The following is a description of a gene set: Genes up-regulated in lung adenocarcinoma cell lines and not expressed in non-cancerous lung epithelial cells. species: Homo sapiens Human Gene Set: NAKAMURA_LUNG_CANCER To identify tumor markers and differentiation markers for lung adenocarcinoma (AdC), we analysed expression profiles of genes against three cases of type II alveolar epithelial cells, bronchiolar epithelial cells, and bronchial epithelial cells, respectively, and 10 cases of AdC cells isolated by laser capture microdissection. Hierarchical clustering analysis indicated that AdC cells and noncancerous lung epithelial cells are significantly different in their expression profiles, and that different sets of differentiation markers are expressed among alveolar, bronchiolar and bronchial epithelial cells. Nine genes were identified as being highly expressed in AdC cells, but not expressed in noncancerous lung epithelial cells. Sixteen genes were identified as differentiation markers for lung epithelial cells. Real-time RT-PCR analysis of 45 lung AdC cases further revealed that expression of four tumor markers in AdC cells was significantly higher than that in noncancerous lung cells and that expression of ten differentiation markers was retained in a considerable fraction of lung AdC cases. Five tumor markers and seven differentiation markers were not expressed in peripheral blood cells. Similarities and differences in expression profiles between normal epithelial cells from different lung respiratory compartments and AdC cells demonstrated in this study will be informative for the molecular diagnosis of lung AdC. from publication Nakamura N, Kobayashi K, Nakamoto M, Kohno T, Sasaki H, Matsuno Y, Yokota J (PMID 16491115), and this is the list of marker genes: MCM6, TOP2A, SCG5, COL11A1, ATP10B, TFPI2 (NCBI Gene Id 7980), XAGE1A, AURKA, TM4SF4